The following is a description of a gene set: Mouse Gene Set: REACTOME_KERATAN_SULFATE_KERATIN_METABOLISM studied in species Mus musculus Keratan sulfate/keratin metabolism, and this is the list of marker genes: St3gal1, Acan, Gns, Chst2, Omd, B3gnt3, St3gal2, Ogn, Glb1, B4galt5, Slc35d2, St3gal3, Glb1l, B3gnt2, B3gnt4, Hexa, B4galt1, Hexb, Chst5, B4galt3, Glb1l3, Galns, Glb1l2, B4galt6, B4galt2, B4gat1, St3gal6, Prelp, Fmod, St3gal4, B3gnt7, Kera, Lum, Chst1, B4galt4